The following is a description of a gene set: Cytokines mediate cell-cell communication in the immune system and represent important therapeutic targets. A myriad of studies have highlighted their central role in immune function, yet we lack a global view of the cellular responses of each immune cell type to each cytokine. To address this gap, the authors created the Immune Dictionary, a compendium of single-cell transcriptomic profiles of more than 17 immune cell types in response to each of 86 cytokines (>1,400 cytokine-cell type combinations) in mouse lymph nodes in vivo. A cytokine-centric view of the dictionary revealed that most cytokines induce highly cell-type-specific responses. For example, the inflammatory cytokine interleukin-1β induces distinct gene programmes in almost every cell type. A cell-type-centric view of the dictionary identified more than 66 cytokine-driven cellular polarization states across immune cell types, including previously uncharacterized states such as an interleukin-18-induced polyfunctional natural killer cell state. studied in species Mus musculus Genes positively differentially expressed in cell type: B cell upon treatment with cytokine: IFN-κ in mouse lymph nodes in vivo. from publication Cui A, Huang T, Li S, Ma A, Pérez JL, Sander C, Keskin DB, Wu CJ, Fraenkel E, Hacohen N (PMID 38057668) Mouse Gene Set: CUI_B_CELL_IFNK_RESPONSE_UP, and this is the list of marker genes: Daxx, Rtp4, Mitd1, Ifit1, Phf11b, Eif2ak2, Ifit3b, Gbp7, Ms4a4c, Asb13, Pkib (NCBI Gene Id 19081), Samhd1, Psmb8, Irf7, Trafd1, Rsad2, Herc6, Sp100, Ly86, Ifit2, Trim30b, Dnaja1, Usp25, Trim30d, Shisa5, Epsti1, Ifi27l2a, Tapbp, Irgm1, H2-T22, Ifi208, Parp14, Ube2l6, Ifi209, Rnf213, Ifi206, Smchd1, Plac8, Oas3, Tlr7, Ifi203, Selenow, Trim12a (NCBI Gene Id 76681), Stat1, Igtp, Pml, Samd9l, Lgals9, Mx1, Xaf1, BC051226, Ifi35, Slfn5, Ifi47, Tspo, Bst2, Slfn2, Mndal, Zbp1, Sp110, Ifi214, Nmi, Psme2b, Tor3a, Stat2, Ifit1bl1, Lgals3bp, Ly6a, Trim12c, Trim30a, Helz2, Rigi, Ifitm3, Isg15, Sp140, Cybb, Trim34a, 9930111J21Rik2, Oasl1, Slfn8, Psme1, Isg20, Cd47, Ifit3, Usp18, Zup1, Parp9, Ifi213, Dhx58, Oasl2 (2'-5' oligoadenylate synthetase-like 2)